Given this list of marker genes Mcm6, Ssrp1, Cbx5, Ncapd2, Prkdc, Top2a, Pold2, Rad50, Smc4, Tmpo, Gins1, Eed, Prdx4, Mthfd2, Rad51c, Cdkn1b, Mcm4, Nup107, Ddx39a, Cenpe, Lsm8, Chek1, Mcm3, Timeless, Syncrip, Suv39h1, E2f8, Cdca3, Cdc25a, Plk1, Eif2s1, Nop56, Donson, Spc24, Hmgb3, Pnn, Ccp110, Stag1, Rpa3, Cdkn2a (cyclin dependent kinase inhibitor 2A), Tk1, Paics, Psip1, Ak2, Orc2, Prim2, Cnot9, Myc, Shmt1, Mxd3, Prps1, Tcf19, Rfc1, Rad1, Nap1l1, Rbbp7, Psmc3ip (proteasome (prosome, macropain) 26S subunit, ATPase 3, interacting protein), Cdkn3, Aurka, Ccnb2, Xrcc6, Tra2b, Cdkn1a, Asf1a, Tipin, Lmnb1, H2ax, Tbrg4, Gins4, Mcm5, Zw10, Orc6, Pole4, Wee1, Nup153, Pcna, Hus1, Dnmt1, Cdk1, Gins3, Cit, Phf5a, Cdkn2c, Cdca8, Nasp, Ctcf, Cks1b, Mlh1, Spc25, Stmn1, Usp1, Hmmr, Rfc3, Luc7l3, Pds5b, Kif22, Rpa1, Tacc3, Trip13, Msh2, Ran, Rpa2, Exosc8, Dek, Nbn, Srsf1, Tubb5, Kif4, Cenpm, Lig1, Ung, Atad2, Rad21, Dclre1b, Cse1l (NCBI Gene Id 98761), Nup205, Dscc1, Ipo7, Melk, Dck, Mki67, Cks2, Ing3, Pola2, Nolc1, Bard1, Hells, Birc5, Mcm7, Mad2l1, Dut, Tubg1, Diaph3, Kif2c, Hmga1b, Nme1, Ube2s, Lyar, Smc1a, Rnaseh2a, Smc3, H2az1, Pold1, Chek2, Dctpp1, Pttg1, Racgap1, Trp53, Mre11a, Anp32e, Brms1l, Mcm2, Rfc2, Pan2, Ppm1d, Pop7, Plk4, Smc6, Xpo1, Ilf3, Cdk4, Jpt1, Espl1, Depdc1a, Cdc25b, Snrpb, Asf1b, Pa2g4, Rrm2, Gspt1, Srsf2, Spag5, Ctps1 (cytidine 5'-triphosphate synthase 1), Pole, Ppp1r8, Slbp, Hnrnpd, Lbr, Wdr90, Brca1, Ezh2, Mms22l, Mybl2, Ubr7, Nudt21, Pold3, Ranbp1, Tfrc, Cdc20, Rad51ap1, Dlgap5, Pms2, Bub1b, Brca2 (breast cancer 2, early onset), Ccne1, Hmgb2, Ube2t, Aurkb, Kif18b, here is a description of the gene set: species: Mus musculus Mouse Gene Set: HALLMARK_E2F_TARGETS from publication Howe DG, Blake JA, Bradford YM, Bult CJ, Calvi BR, Engel SR, Kadin JA, Kaufman TC, Kishore R, Laulederkind SJF, Lewis SE, Moxon SAT, Richardson JE, Smith C (PMID 30224793) Mouse genes annotated to HALLMARK_E2F_TARGETS based on orthology mappings provided by the Alliance Genome Consortium